The following is a description of a gene set: Human Gene Set: WP_CONTROL_OF_IMMUNE_TOLERANCE_BY_VASOACTIVE_INTESTINAL_PEPTIDE Control of immune tolerance by vasoactive intestinal peptide species: Homo sapiens, and this is the list of marker genes: CD28 (CD28 molecule), IFNG, IL10, IL5, IL4, IL2, VIP, CD80, CTLA4, IL12A, TGFB1, CD86, FAS